The following is a description of a gene set: studied in species Homo sapiens Human Gene Set: WP_SARSCOV2_INNATE_IMMUNITY_EVASION_AND_CELLSPECIFIC_IMMUNE_RESPONSE SARS-CoV-2 innate immunity evasion and cell-specific immune response, and this is the list of marker genes: CXCL8, IL10, IFNAR2, HDAC2, CD160, SMAD3, MAVS, CXCR2 (NCBI Gene Id 3579), TRIM25 (NCBI Gene Id 7706), TRAF6, TRAF5, IFNB1, CCL2, IFITM1, TRAF2, TP53I3, HAVCR2, TANK, BSG, AP1G1, CXCL12, CXCL9, EP300, LARP1, DHX58, STAT1, IFIT2, TRAF3, CCL5, CXCL2, IRF3, TLR7, CXCL10, CCL4, CCL3, CSF2, TNF, CXCL13, CXCL17, CASP8, NUP98, RAE1, ACE2, CXCL1, IL6, RIGI, RIPK1, TFAP2A, JAK1, PF4, IRF7, TRADD, CXCL3, CXCL11 (NCBI Gene Id 6373), IFNAR1, STAT2, FADD, CXCL5, TBK1, CXCL6, NFKB1, IL6R, TGFB1, PPBP, MX1, LAG3